The following is a description of a gene set: Any process that results in a change in state or activity of a cell (in terms of movement, secretion, enzyme production, gene expression, etc.) as a result of a L-leucine stimulus. Mouse Gene Set: GOBP_CELLULAR_RESPONSE_TO_L_LEUCINE species: Mus musculus, and this is the list of marker genes: Ubr1, Ubr2, Mtor, Sesn3, Sesn1, Stambpl1, Ep300, Klhl22, Rptor, Rragd, Lars1, Hnf1a, Sesn2